The following is a description of a gene set: Human Gene Set: GAUTAM_EYE_IRIS_CILIARY_BODY_WIF1_HIGH_FIBROBLASTS from publication Gautam P, Hamashima K, Chen Y, Zeng Y, Makovoz B, Parikh BH, Lee HY, Lau KA, Su X, Wong RCB, Chan WK, Li H, Blenkinsop TA, Loh YH (PMID 34584087) Occular cell types curated from Gautam and Hamashima et al. Multi-species single-cell transcriptomic analysis of ocular compartment regulons species: Homo sapiens, and this is the list of marker genes: RPL13, FHL2, CTSC, LAMC3 (NCBI Gene Id 10319), CDKN1A, RACK1, ZNF703, DPYSL3 (NCBI Gene Id 54406), RPL24, BTG3 (BTG anti-proliferation factor 3), RPS3, TUBB4B, GBP2, NR2F1, SNORD3A, GMDS, HIC1, CHEK2, TGIF1, TRIB3, FMOD (NCBI Gene Id 2331), PTP4A2, SNHG8, PLPP3, RPL34, DIO3OS, CPPED1, RPSA2, TLE5, RSL1D1, TMBIM1, AKR1C3, EEF1D, GNB2, TSC22D3, LSAMP, ADD3, WBP1L, MT1X, CSRP1 (cysteine and glycine rich protein 1), SSR2, RPS23, RPL8, H1-0, CTTNBP2, SUMO2, STOM (NCBI Gene Id 2040), RPL5, EID1, IFI44L, ZNF385A, HNRNPA1L2, ADIRF, RPL15, ITM2B, KCNAB1, MLLT11, TMEM176A, RAMP2-AS1 (NCBI Gene Id 100190938), CSGALNACT2, NPM1, CMBL, TGFBI, RSPO2 (NCBI Gene Id 340419), SCARA5, NHERF2, TMEM45A, PAPPA, NECAB1, FHL1, TMEM176B, MT1E (metallothionein 1E), SOD3, LUM, EEF2, CDH11, RPL7, RPS14, ANG, NDN, TBC1D4, RPL41, PRRX1, TNFRSF1A (TNF receptor superfamily member 1A), FOSB, EIF1, CALD1 (NCBI Gene Id 800), ELOVL5 (NCBI Gene Id 60481), RASD1, CMTM8, FCGRT, RPS4X, LDHA, ADAMTSL3 (ADAMTS like 3), RPL6, FLYWCH2, BZW1, RPS9, RPS5, RPS8, ARID5B, TPM4, CHI3L2, RPL13A, RPS18, TMSB4X, RPL17, C1RL, SEPTIN4, ECRG4, MT1M, GLCE, GPR37, KLF9, ARRDC3, RPL21, FOS, RPL26, EMX2, CCDC71L, RGL3, LARP6, CYP1B1